The following is a description of a gene set: Mouse Gene Set: GOBP_NEGATIVE_REGULATION_OF_MONOATOMIC_ION_TRANSPORT studied in species Mus musculus Any process that stops, prevents, or reduces the frequency, rate or extent of the directed movement of charged atoms or small charged molecules into, out of or within a cell, or between cells, by means of some agent such as a transporter or pore., and this is the list of marker genes: Gstm7, Fcrl5, Mmp9 (NCBI Gene Id 99431), Drd2, Spink1, Best3, Wnk1, Nherf1, Hsd3b6, Sri, Akt1 (thymoma viral proto-oncogene 1), Tlr9, Grp (gastrin releasing peptide), Gpr35, Kcne3, Atf4, Kcnq1, Hrc, Kcne1, Ppp3cb, Dysf, Cav3 (caveolin 3), Hamp2, Kcnab1, Hamp, Wnk2, Cd300a, Eppin, Kcne2, Cav1, Ptgs2, Nos3, Smim6, Mcub, Tgfb2, Ywhaq, Ank3, Vip, Ppif, Stk39, Calm3, Bin1, Inpp5k, Bcl2, Ptger3, Calm1, Ntsr1, Nedd4l, Actn2, Htr1b, Drd4, Hes1, Ace, Crhr2, Htr7, Hsd3b3, Wnk4, Tmbim6, Wfdc6a, Kel, Gopc, Gnao1, Pkd2, Kcne5, Atp1a2, Zfas1, Agrn, Epo, Iscu, Ywhae, Cbarp, Ppp3ca, Commd1, Wnk3, Gsto1, Pxk, Ubr3, Mrln, Ptk2b, Ahr, Ppp3r2, Fkbp1b, Crbn, Trim27, Fmr1 (fragile X messenger ribonucleoprotein 1), Hrh3, Sumo1, Trdn, Pln, Pik3c2a, Osr1, Serpine2, Hsd3b2 (NCBI Gene Id 15493), Gnaq, Prkg2, Maob, Oxsr1 (oxidative-stress responsive 1), Pcsk9, Prkce, Rgs4, 1810037I17Rik, Calm2, Pacsin3, Slc26a5, Rem1, Cacna1f, Kcnh2, Casq2, Mtor, Pawr, Nos1, Gnb5, Kcnrg, Stc1, Nedd4, Hcrt, Ucp2, Fbxo11, Ppp3cc, Ppp3r1, Cnr1, Sestd1, Plcb4, Ubqln1, Adcyap1, Slc30a1, Vdac1, Sln, Tgfb1, Akap5, Camk2d, Icam1, Atp7a, Usp2, Htr2a